Given this list of marker genes TSPAN14, HES1, FOXC1, EBF1, ITGA8, EGFL7, ENTPD1, ECE1, HMCN1, ADGRF5, CDH11, COL18A1, TMEM88, ECSCR, HYAL2, CAV2, EFNB2, PTPRB, ST6GAL1, EFNA1, LEPROT, EHD2, PODXL, CD9, KDR, ADGRG6, ACKR3, INPP1, RASIP1, MMRN2, VAMP5, MSN, CLEC3B, MGST2, TGM2, ID1, RAMP2, PLPP3, S100A16, PECAM1, TNFRSF1A, NICOL1, LY6E, FCGRT, VWF, CALCRL, ARHGAP29, CLEC14A, CAVIN2, PLK2, NPR1, CGNL1, CYYR1, RDX, TM4SF1, PLVAP, PCDH7, MMRN1, SPINT2, HLA-E, KLHL4, RALB, ENG, RHOC, ITGA5, IL33, PLTP, AFAP1L1, CD34, ADAMTS9, LDB2, NECTIN2, ELK3, NPR3, NRP1 (NCBI Gene Id 8829), NT5E, BMPER, STOM, NOTCH1, TSPAN7, SLC27A3, WWTR1, F11R, EPHB4, SNCG, ALDH2, PPP1R14A, THSD7A, FLT1, PON2 (NCBI Gene Id 5445), ANGPTL4, CLIC1, CTHRC1, CDH5, ITPR1, SCARF1, NOS3, TIE1, LEPR, BMX, FKBP1A, ESAM, SCARB2, SMAGP, TMEM204, F2R, ETS1, DUSP6, COLEC11, TSPAN18, TMEM100, SLCO2A1, PRCP (NCBI Gene Id 5547), PALMD, F8, TEK, C1orf54, GJA4, SNRK, RAPGEF5, ROBO4, FXYD5, IFITM2, PLXND1, SOX7, FXYD6, GNG11, NPDC1, MYCT1, TFPI, EMCN, IGFBP4 (NCBI Gene Id 3487), NOSTRIN, CD93, FZD6, NRP2, LRIG3, EDNRB, MCAM, PROCR, PCAT19, QSOX1, ST6GALNAC3, CHSY1, POSTN (NCBI Gene Id 10631), GMDS, here is a description of the gene set: species: Homo sapiens from publication Cui Y, Zheng Y, Liu X, Yan L, Fan X, Yong J, Hu Y, Dong J, Li Q, Wu X, Gao S, Li J, Wen L, Qiao J, Tang F (PMID 30759401) Human Gene Set: CUI_DEVELOPING_HEART_C4_ENDOTHELIAL_CELL